The following is a description of a gene set: species: Mus musculus Mouse Gene Set: SASAI_TARGETS_OF_CXCR6_AND_PTCH1_UP from publication Sasai K, Romer JT, Kimura H, Eberhart DE, Rice DS, Curran T (PMID 17413002) The sonic hedgehog (Shh) pathway is activated in approximately 30% of human medulloblastoma resulting in increased expression of downstream target genes. In about half of these cases, this has been shown to be a consequence of mutations in regulatory genes within the pathway, including Ptc1, Smo, and Sufu. However, for some tumors, no mutations have been detected in known pathway genes. This suggests that either mutations in other genes promote tumorigenesis or that epigenetic alterations increase pathway activity in these tumors. Here, we report that 3% to 4% of mice lacking either one or both functional copies of Cxcr6 develop medulloblastoma. Although CXCR6 is not known to be involved in Shh signaling, tumors derived from Cxcr6 mutant mice expressed Shh pathway target genes including Gli1, Gli2, Ptc2, and Sfrp1, indicating elevated pathway activity. Interestingly, the level of Ptc1 expression was decreased in tumor cells although two normal copies of Ptc1 were retained. This implies that reduced CXCR6 function leads to suppression of Ptc1 thereby increasing Smoothened function and promoting tumorigenesis. We used a direct transplant model to test the sensitivity of medulloblastoma arising in Cxcr6 mutant mice to a small-molecule inhibitor of Smoothened (HhAntag). We found that transplanted tumors were dramatically inhibited in mice treated for only 4 days with HhAntag. These findings suggest that HhAntag may be effective against tumors lacking mutations in known Shh pathway genes. Up-regulated genes in medulloblastoma tumors from heterozygotic CXCR6 knockout mice compared to those from PTCH1 heterozygotic knockout mice., and this is the list of marker genes: Xist, Ttr, Otx2, ENSMUSG00000139834, Iffo2, Slc1a5, Foxd1, Ppfia4, Plcb4, Uqcr10, Vgf, L1cam, Rnf112, Mndal, Gdpd3